The following is a description of a gene set: studied in species Homo sapiens A collagen heterotrimer containing type XI alpha chains in alpha1(XI)alpha2(XI)alpha3(XI) trimers; type XI collagen triple helices associate to form fibrils. Human Gene Set: GOCC_COLLAGEN_TYPE_XI_TRIMER, and this is the list of marker genes: COL28A1, COL5A1, COL11A1, COL11A2, COL2A1, COL5A2